The following is a description of a gene set: Reactome Pathway: TFAP2 (AP-2) family regulates transcription of cell cycle factors electronically inferred by orthology from the curated human pathway species: Mus musculus part of: Transcriptional regulation by the AP-2 (TFAP2) family of transcription factors This event has been computationally inferred from an event that has been demonstrated in another species.<p>The inference is based on the homology mapping from PANTHER. Briefly, reactions for which all involved PhysicalEntities (in input, output and catalyst) have a mapped orthologue/paralogue (for complexes at least 75% of components must have a mapping) are inferred to the other species., and this is the list of marker genes: Myc